The following is a description of a gene set: Mouse Gene Set: SAP30_TARGET_GENES studied in species Mus musculus Genes containing one or more binding sites for (Sap30) in their promoter regions (TSS -1000,+100 bp) as identified by GTRD version 20.06 ChIP-seq harmonization. from publication Yevshin I, Sharipov R, Kolmykov S, Kondrakhin Y, Kolpakov F (PMID 30445619), and this is the list of marker genes: Ccna2, Ccnf, Epo, Bloc1s1, Rexo4, Sugp2, Dcp1a, Nkapd1, Mrpl48, Slc11a2, Nufip1, Snx5, Cacng2, Cul7, Sugp1, Cltc, Tas1r1, Tpk1, Tmem101, Nrp2, Gtf3c6, Ythdf2, Rfc5, Pih1d2, Ccdc77, 4930532G15Rik, Mettl4-ps1, Rrp15, Dph1, Rcl1, Tex14, Actb, Pbk, 2700038G22Rik, Crebl2, Smc4, Trmt61a, Utp20, Tpx2, Ddx51, 1700125G22Rik (RIKEN cDNA 1700125G22 gene), Nnt, Ap4m1, Pabpc4, Gdf9, Kdm5a, Gm13610, Gm6288, Noc4l, Krr1, Cenpf, Dnajc16, Syncrip, Cpsf1, Mms22l, 1110059G10Rik, Rpl23 (NCBI Gene Id 80497), Uqcrq, H3c8 (H3 clustered histone 8), Pgk1, Wdr1 (WD repeat domain 1), Thrap3, 4933440N22Rik, Edem1, Taf4, Sec11c, Zc3h7a, Mir7b (NCBI Gene Id 723883), Zfp768, Psme3 (NCBI Gene Id 19192), Nol9, Arl16, Nuak1, Zdhhc7, Foxj3, Cdca2, Rps19, Tatdn3, Birc5, Upf3a, Zfp113, Rnf10, Kif2c, Dnaja3, Map3k12, Fam53a, Micos10, Tacc3, Clpp, Map1lc3b, Sdad1, Knl1, Brd9, Psen2, Aurka, Gm15728, Bms1, Taf1a, Ppp4r1l-ps, Frg2f1, Rdh5, Taf4b, Nuf2, Nudc, Snora21, Dgka, Tmem129, Gm31728, Gins3, Rnu11, Hspa9, Dnajc1, Meaf6, Zfp365, Ccnb2, 2700099C18Rik, H3c3, Mcm3ap, Usp4, D330041H03Rik, Hmgn2, Abhd13, Snx18, Dcaf10, Rbck1, Ube2q1, Zer1, Ddx55, 4921531C22Rik, Rimoc1, Cmss1, Mtfr2, Gar1, Ipo7, Chmp6, Ect2, Pabir1 (NCBI Gene Id 73676), Triobp, Asic3, 2500002B13Rik, Mettl4, Tmem64, Dhx40, Gm15545, Med26, Nppb, Polk, Stx16, Lrrc24, Dgcr8, Bdnf, Sass6, Pou2f1, Ctbp2, A130014A01Rik, Eprs1, Sub1, Eapp, Mfsd6, Gpalpp1, Kif15, A430105J06Rik, Gm2093, Mgme1, Gm5475, Trmt13, Aimp1, Naa40, Smad5, Rnaseh2b, Gnb2, Rest, Mcm7, Kctd9, Scaf8, Ulk4, Zfp688, Polg, Trip13, A230056P14Rik, Cnst, Haspin, B4galt7, Scrt1, Mcph1, Cdkn2aipnl, Pomt1, Tfap4, Nipa2, Cdc25a, Pdik1l, Ppp2r5a, Bub1, Tfb2m, Rbm17, Amfr, Rtel1, Vti1b, Fos, Cenpu, Atp6v0a2, Atad2, Cfap298, Mis18bp1, Cyp51, Ppp1r9b (NCBI Gene Id 217124), Smc6, Nbn, Nsl1, Lig4, Micu2, Glyr1, Ncam1, Opa1, Slc25a32, Ndc80, Lrp11, 4632404H12Rik (NCBI Gene Id 74034), Gm9903, 3110082I17Rik, Rgl2 (NCBI Gene Id 19732), 3110083C13Rik, Trp53inp1, Adgrb3, Ift80, Gprin1, Dleu2, Sirt1, Rcc1, Nploc4, Pprc1, Haus6, Tbck, Dcaf13, Trmt2a, Gm27017 (predicted gene, 27017), Trim27, Ranbp1, Fscn1 (fascin actin-bundling protein 1), Pcmtd1, Polr3b, Rab11a, Sucla2